The following is a description of a gene set: Up-regulated genes in A2780 cells (ovarian cancer) treated with 17AAG, a chemical with anticancer properties. from publication Maloney A, Clarke PA, Naaby-Hansen S, Stein R, Koopman JO, Akpan A, Yang A, Zvelebil M, Cramer R, Stimson L, Aherne W, Banerji U, Judson I, Sharp S, Powers M, deBilly E, Salmons J, Walton M, Burlingame A, Waterfield M, Workman P (PMID 17409432) Human Gene Set: MALONEY_RESPONSE_TO_17AAG_UP The promising antitumor activity of 17-allylamino-17-demethoxygeldanamycin (17AAG) results from inhibition of the molecular chaperone heat shock protein 90 (HSP90) and subsequent degradation of multiple oncogenic client proteins. Gene expression microarray and proteomic analysis were used to profile molecular changes in the A2780 human ovarian cancer cell line treated with 17AAG. Comparison of results with an inactive analogue and an alternative HSP90 inhibitor radicicol indicated that increased expression of HSP72, HSC70, HSP27, HSP47, and HSP90beta at the mRNA level were on-target effects of 17AAG. HSP27 protein levels were increased in tumor biopsies following treatment of patients with 17AAG. A group of MYC-regulated mRNAs was decreased by 17AAG. Of particular interest and novelty were changes in expression of chromatin-associated proteins. Expression of the heterochromatin protein 1 was increased, and expression of the histone acetyltransferase 1 and the histone arginine methyltransferase PRMT5 was decreased by 17AAG. PRMT5 was shown to be a novel HSP90-binding partner and potential client protein. Cellular protein acetylation was reduced by 17AAG, which was shown to have an antagonistic interaction on cell proliferation with the histone deacetylase inhibitor trichostatin A. This mRNA and protein expression analysis has provided new insights into the complex molecular pharmacology of 17AAG and suggested new genes and proteins that may be involved in response to the drug or be potential biomarkers of drug action. species: Homo sapiens, and this is the list of marker genes: NFIL3, EEF2, HSPA8, ATP5MC2, UBA1, ARPC3, STX5, CTSH, HSPA1B, KCNB1, MYL9, EPHA1, CCL14, CAPN1, CCNI, IGFBP2, NEFM, PDAP1, SPTAN1, PCOLCE, CPZ, PTPRU, PLTP, KLF10 (NCBI Gene Id 7071), TAF1C, CAP2, UCP2, STAT6 (signal transducer and activator of transcription 6), IFITM2, SMARCC2, SOX12, KSR1, MNDA, SERPINB9 (NCBI Gene Id 5272), ST13, SERPINH1, SLC25A6, TARBP2, HTR2B, TAF10